Given this list of marker genes Pabpc2, Vmn2r129, Uts2r, Pvalb, Trgc1, Mllt11, Sel1l, Efnb3, Pdia6, Pgk2, Ckb, Klf10, Lcn2, Myt1l, Tob1, Mettl3, Krt17, Cnr1, Ppie, Klra7, Fabp4, Tcf15, Canx, Tuba3a, Nupr1, Serpine1, Ccn1, Il1a, Gata4, H2-D1, H2-Q4, Gzma, Vcam1, H2-Q10 (NCBI Gene Id 15007), here is a description of the gene set: studied in species Mus musculus Protein arginine methyltransferases (PRMTs) have been implicated in transcriptional activation and repression, but their role in controlling cell growth and proliferation remains obscure. We have recently shown that PRMT5 can interact with flag-tagged BRG1- and hBRM-based hSWI/SNF chromatin remodelers and that both complexes can specifically methylate histones H3 and H4. Here we report that PRMT5 can be found in association with endogenous hSWI/SNF complexes, which can methylate H3 and H4 N-terminal tails, and show that H3 arginine 8 and H4 arginine 3 are preferred sites of methylation by recombinant and hSWI/SNF-associated PRMT5. To elucidate the role played by PRMT5 in gene regulation, we have established a PRMT5 antisense cell line and determined by microarray analysis that more genes are derepressed when PRMT5 levels are reduced. Among the affected genes, we show that suppressor of tumorigenicity 7 (ST7) and nonmetastatic 23 (NM23) are direct targets of PRMT5-containing BRG1 and hBRM complexes. Furthermore, we demonstrate that expression of ST7 and NM23 is reduced in a cell line that overexpresses PRMT5 and that this decrease in expression correlates with H3R8 methylation, H3K9 deacetylation, and increased transformation of NIH 3T3 cells. These findings suggest that the BRG1- and hBRM-associated PRMT5 regulates cell growth and proliferation by controlling expression of genes involved in tumor suppression. Genes down-regulated in NIH-3T3 cells (fibroblast) after knockdown of PRMT5 by RNAi. Mouse Gene Set: PAL_PRMT5_TARGETS_DN from publication Pal S, Vishwanath SN, Erdjument-Bromage H, Tempst P, Sif S (PMID 15485929)